Given this list of marker genes Sin3a, Pias1, Ep300, Ring1, Cbx8, Topors, Ddx5, Zfp131, Cbx2, Scmh1, Pias2, Pcgf2, Sumo1, Casp8ap2, Nrip1, Ing2, Cbx4, Ube2i, Daxx, Rnf2, Mrtfa, Pias4, Hipk2, Safb, Phc2, Phc1, Park7, Mbd1, Sumo2, Bmi1, Uhrf2, Ncoa1, Pias3, Npm1, Ddx17, Sumo3, Ctbp1, Phc3, here is a description of the gene set: species: Mus musculus Mouse Gene Set: REACTOME_SUMOYLATION_OF_TRANSCRIPTION_COFACTORS SUMOylation of transcription cofactors